The following is a description of a gene set: Mouse Gene Set: REACTOME_G0_AND_EARLY_G1 G0 and Early G1 species: Mus musculus, and this is the list of marker genes: E2f5, Tfdp1, E2f4, Lin52, Rbl2, Lin9, Ccna2, Ccne2, Dyrk1a, Lin37, Lin54, Ccne1, Hdac1, Rbbp4, Rbl1, Cdk2, Ccna1